Given this list of marker genes DHX58, SLC35D3, RET, IFIT1B (interferon induced protein with tetratricopeptide repeats 1B), COL11A1, USP18, IRF7, SERINC2, here is a description of the gene set: Human Gene Set: HASEGAWA_TUMORIGENESIS_BY_RET_C634R Genes up-regulated in salivary, thyroid and mammary gland carcinomas developed in transgenic mice carrying RET allele with the MEN2A mutation (C634R). from publication Hasegawa T, Enomoto A, Kato T, Kawai K, Miyamoto R, Jijiwa M, Ichihara M, Ishida M, Asai N, Murakumo Y, Ohara K, Niwa Y, Goto H, Takahashi M (PMID 18542059) Germline mutations in the RET tyrosine kinase gene are responsible for the development of multiple endocrine neoplasia 2A and 2B (MEN2A and MEN2B). However, knowledge of the fundamental principles that determine the mutant RET-mediated signaling remains elusive. Here, we report increased expression of mitogen-activated protein kinase phosphatase-2 (MKP-2) in carcinomas developed in transgenic mice carrying RET with the MEN2A mutation (RET-MEN2A). The expression of MKP-2 was not only induced by RET-MEN2A or RET-MEN2B mutant proteins but also by the activation of endogenous RET by its ligand, glial cell line-derived neurotrophic factor (GDNF). MKP-2 expression was also evident in the MKK-f cell line, which was established from a mammary tumor developed in a RET-MEN2A transgenic mouse. Inhibition of MKP-2 attenuated the in vitro and in vivo proliferation of MKK-f cells, which was mediated by the suppression of cyclin B1 expression. Furthermore, we found that MKP-2 is highly expressed in medullary thyroid carcinomas derived from MEN2A patients. These findings suggest that the increased expression of MKP-2 may play a crucial role in oncogenic signaling downstream of mutant RET, leading to deregulation of cell cycle. species: Mus musculus